The following is a description of a gene set: Human Gene Set: GOCC_ATG12_ATG5_ATG16_COMPLEX studied in species Homo sapiens A protein complex required for the expansion of the autophagosomal membrane. In budding yeast, this complex consists of Atg12p, Atg5p and Atg16p., and this is the list of marker genes: ATG16L2, WDFY3, ATG12, ATG16L1, ATG3, ATG5